Given this list of marker genes Fos, Ncoa2, Hspa1b, Klf2, Hspa1a, here is a description of the gene set: from publication Cui A, Huang T, Li S, Ma A, Pérez JL, Sander C, Keskin DB, Wu CJ, Fraenkel E, Hacohen N (PMID 38057668) Genes negatively differentially expressed in cell type: γδ T cell upon treatment with cytokine: IL-5 in mouse lymph nodes in vivo. Cytokines mediate cell-cell communication in the immune system and represent important therapeutic targets. A myriad of studies have highlighted their central role in immune function, yet we lack a global view of the cellular responses of each immune cell type to each cytokine. To address this gap, the authors created the Immune Dictionary, a compendium of single-cell transcriptomic profiles of more than 17 immune cell types in response to each of 86 cytokines (>1,400 cytokine-cell type combinations) in mouse lymph nodes in vivo. A cytokine-centric view of the dictionary revealed that most cytokines induce highly cell-type-specific responses. For example, the inflammatory cytokine interleukin-1β induces distinct gene programmes in almost every cell type. A cell-type-centric view of the dictionary identified more than 66 cytokine-driven cellular polarization states across immune cell types, including previously uncharacterized states such as an interleukin-18-induced polyfunctional natural killer cell state. Mouse Gene Set: CUI_T_CELL_GD_IL5_RESPONSE_DN studied in species Mus musculus